Given this list of marker genes TNRC6B, AGO1, BCL2, AGO4, AGO2, BCL2A1, AGO3, BIRC7, HINT1, DICER1, TNRC6C, POU3F2, MITF, MOV10, SIN3A, TNRC6A, HDAC1, MIR211, TRPM1 (NCBI Gene Id 4308), here is a description of the gene set: Human Gene Set: REACTOME_REGULATION_OF_MITF_M_DEPENDENT_GENES_INVOLVED_IN_APOPTOSIS Regulation of MITF-M-dependent genes involved in apoptosis species: Homo sapiens